Given this list of marker genes Hras, Sos1, Grb2, Shc1, Kras, Plcg1, Fgf17, Fgf8, Fgf18, Frs3, Fgf20, Fgf16, Ptpn11 (NCBI Gene Id 72646), Fgf2, Fgf1 (NCBI Gene Id 14164), Fgf4, Pik3r1, Pik3ca, Fgf23, Fgf5, Gab1, Fgf9, Frs2, Fgfr3, here is a description of the gene set: Downstream signaling of activated FGFR3 studied in species Mus musculus Mouse Gene Set: REACTOME_DOWNSTREAM_SIGNALING_OF_ACTIVATED_FGFR3